The following is a description of a gene set: Isomerism Human Gene Set: HP_ISOMERISM species: Homo sapiens Isomerism in the context of the congenitally malformed heart is defined as a situation where some paired structures on opposite sides of the left-right axis of the body are, in morphologic terms, symmetrical mirror images of each other., and this is the list of marker genes: ZIC3, SMAD2, GDF1, CFC1, CIROP, DNAH9, NODAL, FANCB